The following is a description of a gene set: Human Gene Set: GOBP_REGULATION_OF_NUCLEOBASE_CONTAINING_COMPOUND_TRANSPORT Any process that modulates the frequency, rate or extent of the directed movement of nucleobases, nucleosides, nucleotides and nucleic acids, into, out of or within a cell, or between cells, by means of some agent such as a transporter or pore. species: Homo sapiens, and this is the list of marker genes: IWS1, NUP153, ADORA1, KHDRBS1, NRDE2, SETD2 (NCBI Gene Id 84184), NEAT1, TPR, HHEX, RSC1A1, AKAP8L, DDX39A, ALKBH5 (NCBI Gene Id 54890), CPSF6 (NCBI Gene Id 11052), NSUN2, THOC2, WNK1 (NCBI Gene Id 9872), DHX9, NCBP2